Given this list of marker genes Crocc, Cep68, Rttn, Ctnnb1, Cep135, Sgo1, Nin, Dctn1, Kif3a, Nek2, Cep250, Cep44, Cntln, here is a description of the gene set: Mouse Gene Set: GOBP_CENTRIOLE_CENTRIOLE_COHESION The cell cycle process in which the two centrioles within a centrosome remain tightly paired. species: Mus musculus